The following is a description of a gene set: studied in species Homo sapiens The differentiation of endothelial cells from progenitor cells during blood vessel development, and the de novo formation of blood vessels and tubes. Human Gene Set: GOBP_VASCULOGENESIS, and this is the list of marker genes: SOX18, HAS2, RIN2, TGFBR2, HDAC7, RAPGEF2, HIF1AN, RASA1, ACKR3 (NCBI Gene Id 57007), NOTCH1, GLMN, CUL7, CAV1, EGFL7, ITGAV, KDR, CEACAM1, NTRK2, QKI, PITX2, CITED1, HOXA13, RTN4, RAMP2, WARS2, WT1 (NCBI Gene Id 7490), SHH, HEY1, EGFL8, RRAS, TIPARP, EPHA2, ADM, WNT7B, CD34, HEG1, MIR1-1, MYOCD, EMP2, PAXIP1, TNNI3, SMO, ZFPM2, APELA, PTPRJ, VEGFA, NKX2-5, TIE1, TGFB1, NRP1, YAP1, FOXF1, CITED2, ITGB8, WNT7A, SPRED1, TEAD2, FZD4, ENG, NPR2, CCM2, TBX5, RAP1A, GDF2 (growth differentiation factor 2), TGFBR3, HEY2, ASB4, ZFP36L1, SGPL1, ZMIZ1, GJC1, MYO1E, APLNR, RASIP1, MYO18B, PDGFRB, CTNNB1, JUNB, AGGF1, TMEM100, AMOT, SOX17